The following is a description of a gene set: Reactome Pathway: Early SARS-CoV-2 Infection Events The initial steps of SARS-CoV-2 infection involve the specific binding of the coronavirus spike (S) protein to the cellular entry receptor, angiotensin-converting enzyme 2 (ACE2). The expression and tissue distribution of entry receptors consequently influence viral tropism and pathogenicity. Besides receptor binding, the proteolytic cleavage of coronavirus S proteins by host cell-derived proteases is essential to permit fusion. SARS-CoV has been shown to use the cell-surface serine protease TMPRSS2 for priming and entry, although the endosomal cysteine proteases cathepsin B (CatB) and CatL can also assist in this process. During the intracellular life cycle SARS-CoV-2 express and replicate their genomic RNA to produce full-length copies that are incorporated into newly produced viral particles. Coronaviruses possess remarkably large RNA genomes flanked by 5' and 3' untranslated regions that contain cis-acting secondary RNA structures essential for RNA synthesis. At the 5' end, the genomic RNA features two large open reading frames (ORFs; ORF1a and ORF1b) that occupy two-thirds of the capped and polyadenylated genome. Coronavirus S proteins are homotrimeric class I fusion glycoproteins that are divided into two functionally distinct parts (S1 and S2). The surface-exposed S1 contains the receptor-binding domain (RBD) that specifically engages the host cell receptor, thereby determining virus cell tropism and pathogenicity. Besides receptor binding, the proteolytic cleavage of coronavirus S proteins by host cell-derived proteases is essential to permit fusion. SARS-CoV has been shown to use the cell-surface serine protease TMPRSS2 for priming and entry, although the endosomal cysteine proteases cathepsin B (CatB) and CatL can also assist in this process The release of the coronavirus genome into the host cell cytoplasm upon entry marks the onset of a complex programme of viral gene expression, which is highly regulated in space and time. The translation of ORF1a and ORF1b from the genomic RNA produces two polyproteins, pp1a and pp1ab, respectively. ORF1a and ORF1b encode 15-16 non-structural proteins (nsp), of which 15 compose the viral replication and transcription complex (RTC) that includes, amongst others, RNA-processing and RNA-modifying enzymes and an RNA proofreading function necessary for maintaining the integrity of the >30kb coronavirus genome. The establishment of the viral RTC is crucial for virus replication The release of the coronavirus genome into the host cell cytoplasm upon entry marks the onset of a complex programme of viral gene expression, here divided into early and late. part of: SARS-CoV-2 Infection species: Homo sapiens, and this is the list of marker genes: PIK3C3, TMPRSS2, CHMP2A, S, CHMP7, CHMP4A, ZCRB1, E, N, GPC1, GPC5, CTSL, SARS coronavirus, complete genome, RB1 (RB transcriptional corepressor 1), VHL, HSPG2, pp1a, NRP1, SDC1, M, GPC2 (glypican 2), CHMP6, CHMP4C, SDC4 (NCBI Gene Id 6385), VCP, ISCU, BECN1, CHMP4B, CHMP3, GPC6, PIK3R4 (phosphoinositide-3-kinase regulatory subunit 4, NCBI Gene Id 30849), 7a, rep, 3a, GPC3, UVRAG, SDC2, MAP1LC3B, DDX5, GPC4, AGRN, HAVCR1, CHMP2B, SDC3, FURIN, ACE2